Given this list of marker genes INS, SIGIRR, ASS1, TFRC, EDNRB, F2, IL6R, ITIH4, MBL2, TNFRSF11A, SAA1, F8, CRP, ORM1, STAT3, SAA2, LCN2, APCS, FN1, IL6, REG3G, CEBPB, SERPINA3, IL1A, IL1RN, PTGES, PLSCR1, TNF, MRGPRX1, REG3A, TRPV1, ORM2, HP, IL22, PTGER3, LBP, SAA4, CEBPA, SERPINA1 (NCBI Gene Id 5265), SERPINF2, CD163, IL1B, PTGS2, EPO, AHSG, TNFSF11, APOL2, here is a description of the gene set: species: Homo sapiens An acute inflammatory response that involves non-antibody proteins whose concentrations in the plasma increase in response to infection or injury of homeothermic animals. Human Gene Set: GOBP_ACUTE_PHASE_RESPONSE